Given this list of marker genes SLC39A7, SLC30A2, SLC30A5, SLC39A6, SLC30A1, SLC30A3, SLC39A1, SLC30A8 (NCBI Gene Id 169026), SLC39A14, SLC39A2, SLC39A5, SLC39A3, SLC39A4, SLC39A10, SLC39A8, here is a description of the gene set: Human Gene Set: REACTOME_ZINC_TRANSPORTERS Zinc transporters studied in species Homo sapiens